The following is a description of a gene set: Human Gene Set: HE_LIM_SUN_FETAL_LUNG_C6_MUC16_POS_CILIATED_CELL species: Homo sapiens MUC16+ ciliated from publication He P, Lim K, Sun D, Pett JP, Jeng Q, Polanski K, Dong Z, Bolt L, Richardson L, Mamanova L, Dabrowska M, Wilbrey-Clark A, Madissoon E, Tuong ZK, Dann E, Suo C, Goh I, Yoshida M, Nikolić MZ, Janes SM, He X, Barker RA, Teichmann SA, Marioni JC, Meyer KB, Rawlins EL (PMID 36493756), and this is the list of marker genes: FYB2, PZP, KIAA0513, CORO2B, TNNT3, PITX1, HBB, PLAAT3, MUC4, ITGB4, LARP6, UACA (NCBI Gene Id 55075), APOD, SEC14L3, MAOB, WDR24, MT3, PLAAT2, AQP5-AS1, DPYSL3, CAPN9, ANKUB1, POU2AF1, PAX9, SLC2A10, CES4A, TNFRSF21 (TNF receptor superfamily member 21), SCPEP1, WFDC6, LINC01550, EPPIN, DIAPH2, VCAN, LGR4, CD82, MUC16, TXLNB, TOX3, KLHL5, ITGA2, C14orf132, SLC23A1, PLEKHS1, PRR15, PALLD, KLHL6, CCN2, CXCL17, SLIT1, MB, SMAD3, SEPTIN11, COL28A1, GBP6, AFDN-DT, KRT7, CP, MUC20, CYP2W1, CCDC190, TRPV4, FGF14